Given this list of marker genes Ubc, Crip1, Neat1, Fos, Rgs10, Hspa1b, Selenop, Jund, Klf6, Klf2, Rgcc, Hspa1a (NCBI Gene Id 193740), Hcst, Dnaja1, Rhob, S100a4, H3f3b, Hmgb2, Fosb, Thy1, Vim, Jun, Junb, Tspo, Fxyd5, S100a10, Btg2, Lsp1, Klf4, St3gal6, S100a6, H1f2, here is a description of the gene set: Mouse Gene Set: CUI_T_CELL_GD_TNFA_RESPONSE_DN Cytokines mediate cell-cell communication in the immune system and represent important therapeutic targets. A myriad of studies have highlighted their central role in immune function, yet we lack a global view of the cellular responses of each immune cell type to each cytokine. To address this gap, the authors created the Immune Dictionary, a compendium of single-cell transcriptomic profiles of more than 17 immune cell types in response to each of 86 cytokines (>1,400 cytokine-cell type combinations) in mouse lymph nodes in vivo. A cytokine-centric view of the dictionary revealed that most cytokines induce highly cell-type-specific responses. For example, the inflammatory cytokine interleukin-1β induces distinct gene programmes in almost every cell type. A cell-type-centric view of the dictionary identified more than 66 cytokine-driven cellular polarization states across immune cell types, including previously uncharacterized states such as an interleukin-18-induced polyfunctional natural killer cell state. studied in species Mus musculus Genes negatively differentially expressed in cell type: γδ T cell upon treatment with cytokine: TNF-α in mouse lymph nodes in vivo. from publication Cui A, Huang T, Li S, Ma A, Pérez JL, Sander C, Keskin DB, Wu CJ, Fraenkel E, Hacohen N (PMID 38057668)